Given this list of marker genes MYOM2, NFKBIA, TCF25, H1-4, BTG2, KIR2DL1 (NCBI Gene Id 3802), KIR3DL1, IL32, PTGDS, CHI3L2, here is a description of the gene set: Thirty-eight PBMC samples from 25 patients with IPF and 13 matched controls yielded 149,564 cells that segregated into 23 subpopulations. Classical monocytes were increased in progressive and stable IPF compared to controls (32.1%, 25.2%, 17.9%, respectively, p<0.05). Total lymphocytes were decreased in IPF vs controls, and in progressive vs stable IPF (52.6% vs 62.6%, p=0.035). Tregs were increased in progressive vs stable IPF (1.8% vs 1.1% of all PBMC, p=0.007), although not different than controls, and may be associated with decreased survival (P=0.009 in Kaplan-Meier analysis; P=0.069 after adjusting for age, sex, and baseline FVC). Flow cytometry analysis confirmed this finding in an independent cohort of IPF patients. Fraction of Tregs out of all T cells was also increased in two cohorts of lung scRNA-seq. CCL22 and CCL18, ligands for CCR4 and CCR8 Treg chemotaxis receptors, were increased in IPF. The single-cell atlas of the peripheral immune system in IPF, reveals an outcome-predictive increase in classical monocytes and Tregs, as well as evidence for a lung-blood immune recruitment axis involving CCL7 (for classical monocytes) and CCL18/CCL22 (for Tregs). (From Abstract) Genes downregulated in NK cells from Idiopathic Pulmonary Fibrosis Patients vs. Controls studied in species Homo sapiens from publication Unterman A, Zhao AY, Neumark N, Schupp JC, Ahangari F, Cosme C Jr, Sharma P, Flint J, Stein Y, Ryu C, Ishikawa G, Sumida TS, Gomez JL, Herazo-Maya JD, Dela Cruz CS, Herzog EL, Kaminski N (PMID 38717443) Human Gene Set: UNTERMAN_IPF_VS_CTRL_NK_CELL_DN